The following is a description of a gene set: Blockage of the flow of urine from the bladder into the urethra. Human Gene Set: HP_URETHROVESICAL_OCCLUSION species: Homo sapiens Urethrovesical occlusion, and this is the list of marker genes: IGF2, CHRM3, MID1, NSD1, APC2, SRCAP, BNC2, HNRNPH1, PLEC, ITGB4